Given this list of marker genes ZNF350, SRRM1, SMARCD2 (SWI/SNF related, matrix associated, actin dependent regulator of chromatin, subfamily d, member 2), PSMA6, ATXN3, PHF5A, PIAS4, NCOR2, ALOX5, MAEA, DNTT, KIN, ZNF703, CENPW, IFFO1, DGKQ, ACTL6B, STAG2, SPTBN4, SMC3, BASP1, RNASEL, KIF4B, NUMA1 (NCBI Gene Id 4926), RAD21, BLM, SMARCA4, GFI1B, PHB2, NSMF, DNMT3A, PAXIP1, TEP1, GMCL2, MORC2, BCL11A, RGS12 (regulator of G protein signaling 12), KAT8, LMNB1, AKAP8L, LMNA (NCBI Gene Id 7816), HAT1, KIF4A, PSPC1, UHRF1, THOC1, SMARCB1, RUVBL2, MEN1, SFPQ, POLA1, ATXN7, TP53, OGG1, CFL1, MBD1, MORC3, S100A10, HLTF, GMCL1, ENC1, PML, HNRNPU, KRT18, PBRM1 (NCBI Gene Id 55292), SMARCE1, SMARCC2, GHRHR, ACTL6A, PPIG, CASK, PRKCD, TENM1, NONO, HES1, ERCC8, SPARC, SCAF8, ARID2, SATB1, SMARCD1, FOS, GFI1, CFL2, RUVBL1, CENPF, ATXN1, CAD, AKAP8, PRKCZ, YEATS4, CHMP1A, FIGN, RUNX1T1, DCAF7, NUFIP1, HNRNPM, CXXC1, SATB2, HLCS, TGFB1I1, CEBPB, SMC1A, CLIC4, STAG1, PHACTR3, HNRNPA2B1, SORBS1, ARFGEF1, MATR3, XPOT, KRT8 (NCBI Gene Id 90177), PRPF40A (NCBI Gene Id 55660), SRPK1, CEBPA, LGALS13, ZNF326, YY1, SNW1, ATN1, TINF2, ACTB, VIM, BRD7, LRIF1, MYB, ANXA2, PHF10, AHCTF1, SMARCC1, here is a description of the gene set: A dynamic, proteinaceous framework within the nucleus of eukaryotic cells, composed of proteins and RNA, that provides structural support for chromatin organization, gene regulation, and nuclear processes. species: Homo sapiens Human Gene Set: GOCC_NUCLEAR_MATRIX